The following is a description of a gene set: Mouse Gene Set: MIR_194_2_3P studied in species Mus musculus from publication Chen Y, Wang X (PMID 31504780) Genes predicted to be targets of miRBase v22 microRNA mmu_miR_194_2_3p in miRDB v6.0 with MirTarget v4 prediction scores > 80 (high confidence targets)., and this is the list of marker genes: 6430550D23Rik, Zfp280d, Mras, Vps13b, Mllt10 (NCBI Gene Id 338532), Cct6a, Semp2l1, Cmtm8, Asb15, Bcl10, Plxnb3, St8sia6, Xlr, Tcta, AU018091, Skap1, Exph5, Sox14, Plcxd3, Adgrf2, Eri2, Prr14l, Emilin3, Brcc3, Casp2, Orc2, Mllt6, Nme2, Nipbl, Ahsg, Ctnnd1, Pptc7, Tufm, Grin1, Szrd1, Arhgap32, Cdk18, Hsbp1l1, Hs3st3b1, Cd3d, Ppp1r10, Tomm70a, Rap1gds1, Dhdh, Brat1, Gprin3, Alas1, Arc, Zswim4, Creg2, Cyp2s1, Acly, Mecp2, Kcnj4, Tab2, Kynu, Zfp174, Trim16, Spata13, Prkacb, Zfp175, Phaf1, Hspb7, Pask, Syt12